Given this list of marker genes RFWD3, GALE, MYSM1, SAMD9, MYH9, UBA1, here is a description of the gene set: studied in species Homo sapiens Megakaryocyte dysplasia The presence of micro-megakaryocytes, hypo-lobed, or non-lobed nuclei in megakaryocytes of all sizes and multiple, widely-separated nuclei. Human Gene Set: HP_MEGAKARYOCYTE_DYSPLASIA